Given this list of marker genes Dusp1, Fos, Klf2, Fosb, Stk17b, here is a description of the gene set: Mouse Gene Set: CUI_CDC2_RESISTIN_RESPONSE_DN from publication Cui A, Huang T, Li S, Ma A, Pérez JL, Sander C, Keskin DB, Wu CJ, Fraenkel E, Hacohen N (PMID 38057668) Cytokines mediate cell-cell communication in the immune system and represent important therapeutic targets. A myriad of studies have highlighted their central role in immune function, yet we lack a global view of the cellular responses of each immune cell type to each cytokine. To address this gap, the authors created the Immune Dictionary, a compendium of single-cell transcriptomic profiles of more than 17 immune cell types in response to each of 86 cytokines (>1,400 cytokine-cell type combinations) in mouse lymph nodes in vivo. A cytokine-centric view of the dictionary revealed that most cytokines induce highly cell-type-specific responses. For example, the inflammatory cytokine interleukin-1β induces distinct gene programmes in almost every cell type. A cell-type-centric view of the dictionary identified more than 66 cytokine-driven cellular polarization states across immune cell types, including previously uncharacterized states such as an interleukin-18-induced polyfunctional natural killer cell state. species: Mus musculus Genes negatively differentially expressed in cell type: cDC2 (conventional dendritic cell type 2) upon treatment with cytokine: ADSF in mouse lymph nodes in vivo.